Given this list of marker genes OFD1, PDE4B, ARHGEF7, PAK1, TUBGCP6, CEP57, CDK5RAP2, CEP57L1, GIT1, RAD51D, CENPJ, LYN, NDN, WASH6P, CIMAP3, TUBGCP2, CEP70, B9D2, NDRG1, DIXDC1, WASHC1, RAB11FIP5, TUBGCP4, TUBGCP5, RACGAP1, BLOC1S2, MARK4, WASH3P, BRCA2, FEZ1, BRSK1, WIPF3, NEDD1, DDX3X, TUBGCP3 (tubulin gamma complex component 3), here is a description of the gene set: Binding to the microtubule constituent protein gamma-tubulin. studied in species Homo sapiens Human Gene Set: GOMF_GAMMA_TUBULIN_BINDING